Given this list of marker genes AMPD2, TRIM21, GET1, PSMB5, KPNA2, F2R, TARDBP, SLC19A1, TFRC, CCT3, MGAT4B, SSH1, MAP3K11, CD276, CTH, NOP2, SRSF1, NAP1L1, EXOSC1, HRAS, RPL5, ELOVL1, H2AJ, SLC1A4, CDC23, FRZB, ACOX2, DDX39B, NUDT3, NOP56, NDUFB8, SIX4, MGAT2, CACYBP, AMD1, IMPACT, UBE4B, CCN4, CCNH, TSR1, TIMM9, DDX21, G3BP1 (G3BP stress granule assembly factor 1), TNRC6A, SRM, USP42, MAT2A, NOP58, TAF1D, ACSL5, CSF1, RCL1, RRM2, GTF2E1, GART, PPID, NSL1, TLR2, SRSF5, AKAP8, SCAMP4, SRSF7, PLXNA1, CTPS1, CHN2, FRRS1, HSF1, LZTR1 (NCBI Gene Id 8216), HSPD1, HACD3, ACSL3, MOGS, PPRC1, BZW2, USP46, RCC2, SHMT2, here is a description of the gene set: from publication Gross C, Dubois-Pot H, Wasylyk B (PMID 17704799) Human Gene Set: GROSS_HYPOXIA_VIA_HIF1A_UP The ternary complex factor Net/Elk3 is downregulated in hypoxia and participates in the induction by hypoxia of several genes, including c-fos, vascular endothelial growth factor and egr-1. However, the global role of Net in hypoxia remains to be elucidated. We have identified, in a large-scale analysis of RNA expression using microarrays, more than genes that are regulated by Net in hypoxia. In order to gain insights into the role of Net in hypoxia, we have analysed in parallel the genes regulated by HIF-1alpha, the classical factor involved in the response to hypoxia. We identified about genes that are regulated by HIF-1alpha in hypoxia. Surprisingly, when we compare the genes induced by hypoxia that require either Net or HIF-1alpha, the majority are the same (75%), suggesting that the functions of both factors are closely linked. Interestingly, in hypoxia, Net regulates the expression of several genes known to control HIF-1alpha stability, including PHD2, PHD3 and Siah2, suggesting that Net regulates the stability of HIF-1alpha. We found that inhibition of Net by RNAi leads to decreased HIF-1alpha expression at the protein level in hypoxia. These results indicate that Net participates in the transcriptional response to hypoxia by regulation of HIF-1alpha protein stability. Genes up-regulated in SEND cells (skin endothelium) at hypoxia after knockdown of HIF1A by RNAi. studied in species Mus musculus